Given this list of marker genes Ppard, Ugt1a10, Ffar4, Gpr31b, Stx3, Crabp1, Sh3glb1, Crabp2, Fabp5, Fabp12, Pitpna, Fabp9, Cyp4f40, Gsta1 (glutathione S-transferase, alpha 1 (Ya)), Gstp1, Fabp2 (NCBI Gene Id 14079), Acox1, Gstp3, Cyp4f15, Ugt1a8, Ptgds, Ugt1a7c, Acoxl, Pparg, Insr (NCBI Gene Id 319666), Gstp2, Dbt, Fabp3, Fabp1, Arhgdia, Snca, Prr7 (NCBI Gene Id 432763), Rida, Apoc1, Acox2, Gsta2, Gsta13, Ucp1, Ugt1a9, Dgat1, Alb, Gstp-ps, Pmp2, Id3, Cyp4a14, Tmem175, Rbp7, Cyp4f14, Adh5, Gsta5, Hnf4a, Alox5ap, Acox3, Nme2, Fabp7, Fabp4, Fabp6, Gstm7, Scp2, Cd36, Rbp2, Ffar1, Rbp1, here is a description of the gene set: studied in species Mus musculus Binding to a fatty acid, an aliphatic monocarboxylic acids liberated from naturally occurring fats and oils by hydrolysis. Mouse Gene Set: GOMF_FATTY_ACID_BINDING